Given this list of marker genes CDH23, PPP1R14B, KIF20A, H2BC15, CLDN12, NCAPH, FANCM, DBF4 (NCBI Gene Id 10926), CKS2, LINC01392, LIN9, REXO5, CENPK, RFWD3, SKA3, H3C6, H2BC11, H2AC11, STIL, DEPDC1, CEP85, PTTG1, GGTLC2, ATP6V0A2, EZH2, RFC4, PLK4, ZWINT, MIIP, PPP1R1B, BUB1, ENC1, MEST, MYO3A, SGO1, MTFP1, TMEM108, BCL2L12, E2F7, CEP152 (centrosomal protein 152), ZDBF2, ACBD7, RNASEH2A, POLH, MCIDAS, CDC20, KIF18A, HES6, TACC3, ABLIM2, CCDC158, PREX1, GSKIP, PCCB, MYCL (NCBI Gene Id 4610), SULF2, NEK2, CDK1, CADM1 (NCBI Gene Id 337934), FBN3, PTN, ZNF736, FBXO43, H2AC17, ORC6, RANGAP1, H4C8, C19orf48P, TUBG1, KIF20B, DBNDD1, CCNB1, UBE2C, SPIN4, GPR83, UBE2T, PYGL, PAQR4, CENPF, SLC12A2, RAD51AP1, KIF23, CCDC88A, CDCA4, ZNF469, KRT81, MAP7D3, SPAG5, ZNF788P, MIS18A, PHF7, CEP295, ECT2, MT1G, KNL1, ACOT7, MARCKSL1, CCNB2, CHAF1B, PRC1, CDCA7L, CCDC171, H2AC8, CCDC15, TROAP, MED21, TOP2A, CD19, ANLN, ASF1B, IQCC, TEDC2, NUF2, RACGAP1, ENTPD3, FANCI, TSPAN2, NEU3, USP31, ANKS1B, GLRX, CCDC18, RAD54L, CENPU, BIRC5, TRMT12, DNAH17, UBE2S, FOXM1 (forkhead box M1), SPATS2, LRR1, KIF15, CLDN10, DHFR (dihydrofolate reductase), ASAP2, SLC43A3, MIF4GD, OIP5, CHAF1A, EID3, MUC12, SYT5, HYLS1, MIS18BP1, PLAAT1, TEDC1, TPX2, HMGB3, DLGAP5, FAM216A, CHTF18, POC1A, KNSTRN, AURKA, SGO2, CDT1, YBX2, CCDC14, NUDT6, CDC20B, MELK, NUP93, RCC2, BMAL2, CDKN2D, CCDC178, ERCC6L, CCT6B, CDCA8, ICAM3, MMP23B, PGP (NCBI Gene Id 79118), POGLUT3, MATN2, INSIG1, HDGFL3, H4C2, SLC31A2, RMI1, TBC1D31, WDR62, TRNT1, PLK1, YPEL1 (NCBI Gene Id 94021), LACTB2, H2BC8, CKAP2L, CCDC188, GPSM2, ASPM, SMC2, CTNNBIP1, FAM3B (NCBI Gene Id 54097), DENND6A (NCBI Gene Id 201627), EME1, TYMS, CEP57L1, TTK, HELLS, RASSF1, NUDT15, FOXN4, CENPW, RPL39L, FADD, BARD1, RTTN, BRCA2, BHLHE40, SASS6, CNTROB, H3C10, MAD2L1, DNAH14, TM7SF3, KIF14, CENPJ, COCH, KPNA2, CYTH3, OAT, here is a description of the gene set: studied in species Homo sapiens Human Gene Set: HE_LIM_SUN_FETAL_LUNG_C6_DEUTEROSOMAL_CELL from publication He P, Lim K, Sun D, Pett JP, Jeng Q, Polanski K, Dong Z, Bolt L, Richardson L, Mamanova L, Dabrowska M, Wilbrey-Clark A, Madissoon E, Tuong ZK, Dann E, Suo C, Goh I, Yoshida M, Nikolić MZ, Janes SM, He X, Barker RA, Teichmann SA, Marioni JC, Meyer KB, Rawlins EL (PMID 36493756) Deuterosomal